The following is a description of a gene set: species: Mus musculus Mouse Gene Set: GOBP_GOLGI_RIBBON_FORMATION The formation of a continuous ribbon of interconnected Golgi stacks of flat cisternae., and this is the list of marker genes: Trip11, Prmt5 (protein arginine N-methyltransferase 5), Golga2, Myo18a, Tmed5, Gorasp1, Golph3, Vamp4 (vesicle-associated membrane protein 4), Optn, Fhdc1, Gcc2